Given this list of marker genes Coq6, Coq7, Tamm41, Coq2, Coq3, Coq8a, Dusp18, Coq4, Coq5, here is a description of the gene set: Mouse Gene Set: GOCC_EXTRINSIC_COMPONENT_OF_MITOCHONDRIAL_INNER_MEMBRANE The component of mitochondrial inner membrane consisting of gene products and protein complexes that are loosely bound to one of its surfaces, but not integrated into the hydrophobic region. species: Mus musculus